The following is a description of a gene set: Mouse Gene Set: GOCC_MITOCHONDRIAL_PERMEABILITY_TRANSITION_PORE_COMPLEX A protein complex that connects the inner and outer membranes of animal mitochondria and acts as a pore that can open transiently to allow free diffusion of solutes between the mitochondrial matrix and the cytosol. The pore complex is formed of the voltage-dependent anion channel (VDAC), the adenine nucleotide translocase (ANT) and cyclophilin-D (CyP-D). studied in species Mus musculus, and this is the list of marker genes: Slc25a4, Vdac1, Slc25a31, Bax, Spg7, Ppif, Slc25a5